The following is a description of a gene set: from publication Chen Y, Wang X (PMID 31504780) Genes predicted to be targets of miRBase v22 microRNA mmu_miR_3106_3p in miRDB v6.0 with MirTarget v4 prediction scores > 80 (high confidence targets). Mouse Gene Set: MIR_3106_3P studied in species Mus musculus, and this is the list of marker genes: Ddx3x, Rmi2, Zbtb39, Adam12, Calu, Glrx3, 5730455P16Rik, Ppp3ca, Usp34, 5031439G07Rik (RIKEN cDNA 5031439G07 gene), Cpsf6, 6430550D23Rik, Zfand2a, Eif2b1, Smarca4, Katnal2, Cpeb4, Fem1a, Nr4a2, Rgs8, Slc25a36, Nol9, Scai, Mettl21e, Ptges3, St8sia2, Nr2f2, Myef2, Krtap3-2, Adra2a, Desi2, Rab37, Dusp28, Vkorc1l1, Cenpv, Dscaml1, Fmod, Atxn3, Erlec1, Fes